The following is a description of a gene set: Genes predicted to be targets of miRBase v22 microRNA mmu_miR_466n_5p in miRDB v6.0 with MirTarget v4 prediction scores > 80 (high confidence targets). studied in species Mus musculus Mouse Gene Set: MIR_466N_5P from publication Chen Y, Wang X (PMID 31504780), and this is the list of marker genes: Pcdha12, Bnc2, Keg1, Ccdc66, Ube2j1, Sgk1, Crh, Dclre1b, Mapk6, Zfp945, Mrpl57, Slc35d2, Cand2, Rgs4, App, Ttll1, Znrf3, Shprh, Rgs17, Inhbb, Ppp2r2a, Onecut3 (NCBI Gene Id 246086), Gcnt4, Mpv17, Dtna, Fam163a, Triobp, Cnga2, Dnajc10, Gab3, Arid4a, Pcdhac1, St18, Metrnl, Pcdhac2, C3ar1, Arl13b, Jcad, Acot3, Chst11, Tmbim6, Lpin2, Gas2l3, Mapk10, Cpne8, Adcy9, Gpr22, Orai2, Atrn, Synj1, Nkain2, Pcdha11, Tmem47, Ankrd29, Grik2, Rrm2b, Ttr (transthyretin), Acbd5, Lrrc39, Efna5, Pcdha7, Gria2, Bcas3, Pcdha1, B4galnt2, Pcdha9, Car5b, Pcdha10, Enpp1, Fam169b, Acta2, Adamtsl3, Rars1, Tma16, Pcdha5, Slc24a2, Sin3a, Ctns, Kpna3, Iglon5, Amotl1, Cplx2, Nin, Klkb1, Anks1b (ankyrin repeat and sterile alpha motif domain containing 1B), Ndnf, Foxn3, Dsel, Sec61a2, Adhfe1, Zfp558, Rfx3, Clock, Bmp7 (NCBI Gene Id 12162), Arhgef9, Slc6a19, Pcdha6, Asic2, Wipf3, Adam12, Dscam, Nectin1, Vapb, Tnrc6b, Pcdha3, Cdc25b, Lhfpl6, Zic2, Tmprss3, Lrguk, Elfn1, Pcdha4, Zfp696, Vcf1, Ret, Ddx19b, Cplx3, Gnai3, Mmp21, Pcdhb14, Pcdha2, Daam1, Pcdhb7 (protocadherin beta 7), Slc1a2, Rnase2a, Ncam1, Tppp, Pus10, Scn3b